Given this list of marker genes Npnt, Ing2, Fermt1, Cited2, Hipk2, Flcn, Tgfb1i1, Furin, Tsc22d1, Thbs1, Itga8, Crebbp, Stk11, Zeb2, Rnf111, Cdkn2b, Lrg1, Tgfbr3, Men1, Axin1, Smad4, Got1, Adissp, Hsp90ab1, Gipc1, Slc2a10, Twsg1 (NCBI Gene Id 71539), Myocd, Ep300, Sdcbp, Cdkn1c, Snw1, here is a description of the gene set: Mouse Gene Set: GOBP_POSITIVE_REGULATION_OF_CELLULAR_RESPONSE_TO_TRANSFORMING_GROWTH_FACTOR_BETA_STIMULUS species: Mus musculus Any process that activates or increases the frequency, rate or extent of cellular response to transforming growth factor beta stimulus.